Given this list of marker genes KIF11, KIF4B, CHMP6, CCDC66, HSPA1A, KIF3B, AURKC, CCDC61, POLDIP2, CHMP3, CCSAP, RAB11A, LSM14A (NCBI Gene Id 91161), TPX2, CHEK2, ABRAXAS2, RACGAP1, KIFC1, MAP9, KIF23, SMC1A, STAG2, BIRC5, GOLGA2, HSPA1B, MISP, STAG1, BCCIP, CHMP4BP1 (charged multivesicular body protein 4B pseudogene 1), TPR, UHRF1, MZT1 (mitotic spindle organizing protein 1), ARHGEF10, WRAP73, PLK1, AURKB, NEK2, CHMP1B, KIF4A, HNRNPU, RIPOR2, ABRAXAS1, RANGRF, ZNF207, KIF15, MAP10, PRICKLE1, PDCD6IP, CHMP2A, CLASP2, PIBF1, CEP192, CHMP2B, FLNA, CHMP1A, CEP97, DRG1, OFD1, CDC20, RCC1, SPICE1, MYBL2, SMC3, PRC1, CHMP4B, AAAS, CHMP4A, CHMP5, RHOA, CHMP4C, CHMP7, CLASP1, KPNB1, VPS4B, KIF2A, CDCA8, INCENP, EML3, here is a description of the gene set: Human Gene Set: GOBP_MITOTIC_SPINDLE_ASSEMBLY Mitotic bipolar spindle assembly begins with spindle microtubule nucleation from the separated spindle pole body, includes spindle elongation during prometaphase, and is complete when all kinetochores are stably attached the spindle, and the spindle assembly checkpoint is satisfied. studied in species Homo sapiens